The following is a description of a gene set: Binding to a scaffold protein. Scaffold proteins are crucial regulators of many key signaling pathways. Although not strictly defined in function, they are known to interact and/or bind with multiple members of a signaling pathway, tethering them into complexes. Mouse Gene Set: GOMF_SCAFFOLD_PROTEIN_BINDING species: Mus musculus, and this is the list of marker genes: Syk, Park7, Akap5, Grin2b, Gria1, Shank1, Trem2, Itpr2, Plcg2, Kif1b, Atp2b4, Nlgn3, Cav2, Xiap, Cacna1h, Nlgn4l, Lrp4, Kcna5, Pde4d, Myh9, Mapk3, Krt5, Xrcc6, Kars1, Dsp, Grik1, Kcnq1, Kcnh2, Grm2, Src, Map2k1, Krt15, Shank3 (NCBI Gene Id 58234), Nos1, P2ry1, Chuk, Panx1, Baiap2, Dll1, Cdc37, Gria2, Cd163, Grik2, Dlg4, Git1, Ikbkb, Dynll1, Ubtf, Cacna1g, Ywhae, Scn5a, Krt18 (NCBI Gene Id 16668), Lyn, Nlgn1, Crk, Grk2, Atg4b, Vim, Casp8, Hsp90aa1, Grm3, Braf, Nos3, Homer1, Adcy5, Fyn, Gja1, Ryr2, Map3k7, P2rx7, Phf6, Il6st, Cit, Dlgap3, Casp4, Krt8, Kif5a, Adcy6 (adenylate cyclase 6), Map2k2, Chrna7, Cript, Casp1, Grid2, Trem1, Grin2a, Dynll2, Psap, Tcof1, Nck2